The following is a description of a gene set: species: Mus musculus Mouse Gene Set: REACTOME_INTERLEUKIN_6_SIGNALING Interleukin-6 signaling, and this is the list of marker genes: Ptpn11, Cbl, Tyk2, Il6ra, Stat3, Il6, Il6st (interleukin 6 signal transducer), Socs3, Jak2